The following is a description of a gene set: Reactome Pathway: GSK3B-mediated proteasomal degradation of PD-L1(CD274) studied in species Mus musculus part of: Regulation of PD-L1(CD274) Post-translational modification electronically inferred by orthology from the curated human pathway This event has been computationally inferred from an event that has been demonstrated in another species.<p>The inference is based on the homology mapping from PANTHER. Briefly, reactions for which all involved PhysicalEntities (in input, output and catalyst) have a mapped orthologue/paralogue (for complexes at least 75% of components must have a mapping) are inferred to the other species., and this is the list of marker genes: Psmc2, Psmd1, Psma1, Psmc5, Psmb7, Psma7, Psma5, Psmd13, Psmb4, Psmd6, Rps27a, Cul1, Psma4, Psma2, Psma6, Ubb, Psmc3, Psmb5, Psmc6, Cd274, Psmc4, Psmc1, Psmd12, Psmb6, Psmd7, Psma3